The following is a description of a gene set: A reproductive process occurring in the mother that allows an embryo or fetus to develop within it. species: Mus musculus Mouse Gene Set: GOBP_MATERNAL_PROCESS_INVOLVED_IN_FEMALE_PREGNANCY, and this is the list of marker genes: Nodal, Ndrg3, Cnr1, Angpt2, Stc1, Prl8a2, Ppard, Bsg, Akt1, Med1, Prdx3, Dedd, Parp1, Nr2f2, Vdr, Tppp3, Pla2g4a, Itga3, Mtor, Cyp27b1, Ccl2, Ar, Gja1, Bmpr2, Epor, Cbs, Cdh1, Ash1l, Rxrb, Rgs2, Ptgs2, Ube2a (ubiquitin-conjugating enzyme E2A, NCBI Gene Id 56394), Cited2, Lif, Parp2, Stc2, Mapk1, Kpna6, Dsg2, Pgr, Agrp, Csmd1, Ctsl, Rxra, Adcy7, Ghsr, Ptgis, Havcr2, Ace2, Ptn, Mapk3, Men1, Ndp, Ihh, Dazap1, Ghrl, Prdm1, Stox2, Tmed2, Gjb2, Dcaf13, Ctsb, Kiss1, Junb, Ldoc1, Hmx3, Tcf23, Il11ra1, Wnt4, Esr1